The following is a description of a gene set: Decreased circulating alkaline phosphatase activity Concentration or activity of alkaline phosphatase outside the upper or lower limtis of normal in the blood circulation. Human Gene Set: HP_DECREASED_CIRCULATING_ALKALINE_PHOSPHATASE_ACTIVITY studied in species Homo sapiens, and this is the list of marker genes: ALPL, C18orf32, PIGT, BCR, LIPA, CEBPE, SLC39A4, PIGK, ABL1, PIGS